Given this list of marker genes Gm10069, Hsp90aa1, Ssbp3, 2900052L18Rik, St13, Dhcr24, Hspe1, Phc1, Gm12892, 2210417A02Rik, Xpnpep3, Snx10, Tmed5, Arhgef2, Upp1 (uridine phosphorylase 1), Fkbp4, Gm20652, Zcchc8, Ccdc18, Hspd1, here is a description of the gene set: Mouse Gene Set: ZFP991_TARGET_GENES from publication Yevshin I, Sharipov R, Kolmykov S, Kondrakhin Y, Kolpakov F (PMID 30445619) Genes containing one or more binding sites for (Zfp991) in their promoter regions (TSS -1000,+100 bp) as identified by GTRD version 20.06 ChIP-seq harmonization. species: Mus musculus